The following is a description of a gene set: The process in which the anatomical structures of a neuron projection are generated and organized into branches. A neuron projection is any process extending from a neural cell, such as axons or dendrites. Mouse Gene Set: GOBP_NEURON_PROJECTION_ARBORIZATION studied in species Mus musculus, and this is the list of marker genes: Ssna1, Dvl3, Sema3a, Vps13a, Dvl1, Map3k13, Mfsd2a, Sult4a1, Wnt5a, Mov10, Pak6, Cc2d1a, Ptn, Zfp365, Nrp1, Bcl7a, Dvl2, Rock1, Tuba1a, Lrrk2, Myo9a, Fzd4, Ntng2, Tpbg, Dlg4, Taok2, Phactr1 (NCBI Gene Id 78746), Chrna7, Lrp2, Nlgn1, Afdn, Macf1 (microtubule-actin crosslinking factor 1), Atg16l1, Igf2bp1, Ntng1, Grip1, Cntnap2